The following is a description of a gene set: Mouse Gene Set: MIR_7081_3P studied in species Mus musculus Genes predicted to be targets of miRBase v22 microRNA mmu_miR_7081_3p in miRDB v6.0 with MirTarget v4 prediction scores > 80 (high confidence targets). from publication Chen Y, Wang X (PMID 31504780), and this is the list of marker genes: Acsm2, Stxbp6, Ets1, Klf11, Plekhm3, Rnf40, Tnfaip8l2, Brpf1, Nphp3, Pcgf6, Slc7a14, Mitf, Ube2k, Pctp, Ppm1n, Irag1, Zdhhc9, Ocln, Epc2, Unc5c, Adcy6, Chic1 (cysteine-rich hydrophobic domain 1), Tmem260, Tgm5, Klf6, Mtcl2, Atp6v0a2, Nrp1, Ncam2, Asxl1, Grhl1, Scara3, Ddx5, Glul, Zfand4, Slc1a4, Jazf1, Btg1, Gm6760, Clmn, Wac, Prss16, Usp12, Bbs7, Wiz, Jade2, Tnfaip1, Loxhd1, Arid3a, Tmem167b, Smurf1, Aak1, Csnk2a1, Fcgr4, Hoxc4, Mllt10, Gpr37, Agxt2, Dennd6a, Rnf144b, Pcdh7, Itga9, Zbtb2, Zfp652